Given this list of marker genes PRR12 (NCBI Gene Id 57479), SEPTIN9, SYNE2, ANXA11, C19orf12, TMEM43, CCDC8, POGLUT1, CSGALNACT1, SGCB (NCBI Gene Id 6443), TPM3, KLHL41, FRG1, COL6A2, KCNJ2, MYH2, PYROXD1, OBSL1, DNMT3B, SMCHD1, OPA1, PUS1, DSTYK, MYBPC1, ANO5, BIN1, FLNA, SPEG, FILIP1, POLG, TK2, ACTA1, RYR1, DPAGT1, BAG3, EMD, VCP, GMPPB, KBTBD13, SCN4A (sodium voltage-gated channel alpha subunit 4), EBF3, EMILIN1, SQSTM1, ASH1L, MYPN, TRPS1, ALG14, PAX1, DYSF, LGI4, CUL7, PLIN4, TRPV4, NEFL, LMNA (NCBI Gene Id 7816), TWNK, EYA1, RAF1, GDF11, FBN1, COL6A3, SPRED2, PAX3, GYG1, SGCD, PTPN11, RYR3, SGCG, CRPPA, FLNB, NEB, SGCA, DNM1L, FHL1, VWA1, SYNE1, MYH7, DUX4L1, SPTLC1, TPM2, TTN, COLQ, LAMB2, COL6A1, FLNC, TNPO3, LRIF1, POMT2, COL12A1, GFPT1, TNNT1, ATP6V0A2, TRIO, DUX4, TGFB3, SMPX, ALG2, GNE, CAPN3, BRAF, BICD2 (BICD cargo adaptor 2), here is a description of the gene set: species: Homo sapiens Human Gene Set: HP_SCAPULAR_WINGING Abnormal protrusion of the scapula away from the surface of the back. Scapular winging